The following is a description of a gene set: part of: Translesion synthesis by Y family DNA polymerases bypasses lesions on DNA template Reactome Pathway: Termination of translesion DNA synthesis The initiation and extent of translesion DNA synthesis (TLS) has to be tightly controlled in order to limit TLS-induced mutagenesis, caused by the low fidelity of TLS-participating DNA polymerases. Since monoubiquitination of PCNA at lysine residue K164 is a prerequisite for the assembly of TLS complexes on damaged DNA templates, PCNA deubiquitination is a key step in TLS termination that allows DNA polymerase switching from Y family DNA polymerases involved in TLS to replicative DNA polymerases delta and epsilon. studied in species Homo sapiens, and this is the list of marker genes: POLD3, PCNA, TRIM25, USP43, UBC, POLE, RPA1, UBA52 (NCBI Gene Id 7311), POLD1, UBE2L6, RFC1, POLH, RPA3, RFC2, POLI, USP10, RFC4, PCLAF, REV1, POLE3, POLD2, ISG15, UBA7, POLK, UBB, RPS27A, RPA2, POLD4, RFC3, POLE4, POLE2, RFC5